Given this list of marker genes TRH, GPR17, KRAS, NTS, MCHR2, RGS3, EDN1, ITPR1, GNB2, BDKRB2, PIK3CA, CHRM1, HCRT, KNG1, NPFFR1, BTK, TACR2, P2RY1, CYSLTR1, GRK5, PROK1, DGKI, DGKK, EDN2, PRKCA, GRM5, GNB1, FFAR1, GHRL, TRPC6, XCL1, UTS2, MLN, DAGLA, MLNR, RASGRP2, ITPR3, OPN4, RGS13, ANXA1, CCKBR, DGKZ, CCK, ABHD6, NPFFR2, BRS3, RGS4 (regulator of G protein signaling 4), GNG2, GPR143, GNG11, QRFPR, PIK3R3 (phosphoinositide-3-kinase regulatory subunit 3), GNG8, GNGT1, TRPC3, GPRC6A, NTSR1, GNA11, RGS19, GNA15, RGS16, RGSL1, DGKB, GNRHR2, OXTR, AGTR1 (NCBI Gene Id 9449), ADRA1D, GPR68, ITPR2, PRKCQ, F2R, FPR2, MCHR1, RGS17, UTS2B, HRH1, AGT, GNG10 (G protein subunit gamma 10), GNG7, NMU, GNGT2, GNG12 (NCBI Gene Id 55970), CCKAR, SAA1, PROK2, HTR2C, PIK3R2, GNG5, PTAFR, PLCB1, PLCB2, HRAS, MGLL, GRM1, GNG4, GCG, GNRH1, AVPR1A, FFAR3, SOS1, F2RL1, P2RY2 (purinergic receptor P2Y2), GNRHR, CCL23 (C-C motif chemokine ligand 23), TAC3, GNB5, CREB1, RPS6KA1, AVP, P2RY11, TACR1, RGS1, RPS6KA3, GNB4, QRFP, ABHD12, PRKCE, HCRTR1, XCL2, PLCB3, TAC1, EDNRA, NMUR2, NMS, NMUR1, ADRA1B, GPR132, RASGRP1, DGKQ, GCGR, ADRA1A, MAPK1, LPAR2, OXT, GNAQ, LTB4R2, HTR2A, GNG13, MT-RNR2, CHRM3, UTS2R, NPSR1, LPAR3, GRK2, EGFR, LTB4R, NRAS, F2RL2, APP, GRPR, P2RY6, KALRN, MAPK3, GNA14, HBEGF, F2RL3, GNB3, GAST, FFAR2, PROKR2, CHRM5, GPR4, ARHGEF25, CYSLTR2, XCR1, PTGFR, KISS1R, DGKA, HTR2B, EDNRB, GRP, PRKCH, TACR3, GHSR, RGS2, TRHR, NPFF, DGKH, GPR65, P2RY10, GNRH2, GNG3, EDN3, MAPK7, LPAR1, TRIO, DGKE, HCRTR2, PIK3R1, FFAR4, GRB2, KISS1, DAGLB, CASR, RGS18, NPS, PMCH, TRPC7, NTSR2, NMB, PTGER1, LPAR6, AVPR1B, TBXA2R, RPS6KA2, DGKD, PROKR1, RGS21, GPR39, LPAR4, LPAR5, PLCB4, DGKG, F2, BDKRB1, PRKCD, NMBR, MMP3, RGS5, here is a description of the gene set: species: Homo sapiens The classic signalling route for G alpha (q) is activation of phospholipase C beta thereby triggering phosphoinositide hydrolysis, calcium mobilization and protein kinase C activation. This provides a path to calcium-regulated kinases and phosphatases, GEFs, MAP kinase cassettes and other proteins that mediate cellular responses ranging from granule secretion, integrin activation, and aggregation in platelets. Gq participates in many other signalling events including direct interaction with RhoGEFs that stimulate RhoA activity and inhibition of PI3K. Both in vitro and in vivo, the G-protein Gq seems to be the predominant mediator of the activation of platelets. Moreover, G alpha (q) can stimulate the activation of Burton tyrosine kinase (Ma Y C et al. 1998). Regulator of G-protein Signalling (RGS) proteins can regulate the activity of G alpha (z) (Soundararajan M et al. 2008). Reactome Pathway: G alpha (q) signalling events part of: GPCR downstream signalling